Given this list of marker genes TMX2, RAB7A, DUSP10, HSPB1, HNRNPH2, CRISP3, CPLX2, ALG5, CBLIF, MPST, BHLHE41, SCCPDH, SERINC3, TSG101, NQO2, LAP3, ZKSCAN4, BLCAP, DCTN6, STAB1, EPAS1, PRDX6, PPM1H, COBLL1, SEC62, HS2ST1, ZFAND1, HIGD1A, GSPT1, SEPTIN2, S100A9, EXOSC1, MRPL15, DAPK1, EPB41L3, DAD1, WT1, SLFN12, REXO5, TMEM164, SCML1, TMSB15B, GLRX2, RSL24D1, PISD, IDI2-AS1, FADS1 (fatty acid desaturase 1), ARHGEF6, SEL1L (SEL1L adaptor subunit of SYVN1 ubiquitin ligase), SIL1, CDC42BPA, MITF, BASP1, CMC2, SC5D, ABHD6, E2F6, SNN, CRLF2, ALOX5, SLC48A1, KLHL2, HSPA4, CBS, AMHR2, CHKA, ZCCHC24, RECQL4, HYOU1, TAF10, EXTL2, TFG, MED20, SOCS5, ESYT1, MFAP3L, SLC12A8, PIK3C3, FBP1, AVL9, ADI1, MAFG, TUBB3, ALAS1, QPRT, LPXN, TBC1D8, PICALM, NUP93, SERPINB6, TXNRD1, MEIS2, OSGIN1, BCAT1, AARS1, SMARCD3, NDUFA4, ZNF175, IMPACT, S100A8, FAT1, RDX, MTFR1, SDF2L1, LARP1, MED21, LRP12, GALNT2, MRPL40, CLIP2, POLB, NRP1, TEFM, SLC24A3, TKT, TNFRSF10B, ARMCX3, TAL1, WBP4, SSBP1, LGALS8, YLPM1 (YLP motif containing 1), BAZ2B, RGS19, DAB2, EPB41L2, PSMC4, PDIA4, FCGR2C, TNS3, PEBP1, RTN2 (reticulon 2), INPP5A, PDE8A, ETV5, PPP3CA, PDIA5, ARMC9, CSRNP2, SELENOP, TMEM268, GALNT3, TUBA1B, FES, HEY1 (hes related family bHLH transcription factor with YRPW motif 1), WASHC5, MRPS33, TRAK1, HSPA9, CHN2, ADGRA3, PSMB5, TRIM44, SLC15A3, SMYD3, UBAC1, FLNB, KIAA0753, CTR9, LRRC20, ARL4A, ST13, MARCHF3, ARHGAP6, ZNF516, WDR41, PRDM13, FAM200C, EMC7, OPA1, GABRB2, SH2B3, MCUR1, BACE2, NBEA, ADM, MSRB1, TIMM8B, ZNF124, LTBR, ENY2, ITGBL1, SORBS1, ZNF410, ACY1, FECH, KIF23, UBE2I, ACSL1 (acyl-CoA synthetase long chain family member 1), PINLYP (NCBI Gene Id 390940), FLOT1, H1-0, GMPR, ENPP2, SUOX, TMEM70, SH3BP4, PSMD12, MTHFD1, here is a description of the gene set: In the present study we used Affymetrix oligonucleotide microarrays to produce gene transcription profiles for the major leukocyte types in humans. This comprehensive dataset enabled us to not only establish which genes were expressed in each leukocyte type, but also which genes were expressed in each subset after activation. The used of a comprehensive dataset of gene profiles from all the major human leukocyte subsets enabled a novel and powerful means for identification of genes associated with single leukocyte subsets, or different immune paradigms. Genes up-regulated in comparison of mast cells versus effector memory CD4 T cells. species: Homo sapiens from publication Jeffrey KL, Brummer T, Rolph MS, Liu SM, Callejas NA, Grumont RJ, Gillieron C, Mackay F, Grey S, Camps M, Rommel C, Gerondakis SD, Mackay CR (PMID 16474395) Human Gene Set: GSE3982_MAST_CELL_VS_EFF_MEMORY_CD4_TCELL_UP